The following is a description of a gene set: Human Gene Set: GSE14308_TH2_VS_NATURAL_TREG_DN Genes down-regulated in comparison of Th2 cells versus natural regulatory T cell (Treg). studied in species Homo sapiens Multipotential naïve CD4+ T cells differentiate into distinct lineages including T helper 1 (Th1), Th2, Th17, and inducible T regulatory (iTreg) cells. The remarkable diversity of CD4+ T cells begs the question whether the observed changes reflect terminal differentiation with heritable epigenetic modifications or plasticity in T cell responses. We generated genome-wide histone H3 lysine 4 (H3K4) and lysine 27 (H3K27) trimethylation maps in naïve, Th1, Th2, Th17, iTreg, and natural (n)Treg cells. We found that although modifications of signature cytokine genes (Ifng, Il4, and Il17) partially conform to the expectation of lineage commitment, critical transcription factors such as Tbx21 exhibit a broad spectrum of epigenetic states, consistent with our demonstration of T-bet and IFN-gamma induction in nTreg cells. Our data suggest an epigenetic mechanism underlying the specificity and plasticity of effector and regulatory T cells and also provide a framework for understanding complexity of CD4+ T helper cell differentiation. from publication Wei G, Wei L, Zhu J, Zang C, Hu-Li J, Yao Z, Cui K, Kanno Y, Roh TY, Watford WT, Schones DE, Peng W, Sun HW, Paul WE, O'Shea JJ, Zhao K (PMID 19144320), and this is the list of marker genes: TNRC6C, MEX3D, CMPK2, TAP2, WDR83OS, LIMD1, SEPTIN4, MCM9, PCMTD1, BAIAP3, RNASE6, HTRA2, GRIA2, PYCR2, PPP2R2B, BOD1L1, CDH9, ARV1, STARD5, SLC22A15, TNF, PURG, IVD, FAM13B, ACSF2, PDXK, ZMPSTE24, OSBPL8, CHMP1A, USP7, RBM11, BSDC1, MIA3, RNF31, TES, RBM12, LRCH3, USP32, DGAT2, TSPAN5, FAM241A, FAHD2A, SCN2A, CTU1, TUBGCP5, MKLN1, GSK3A, HEPACAM2, PDZK1IP1, SNX33, RPS6KA3, TMEM35B, CXCL10, CHRNA2, TBX6, EFR3A, CLCN2, LIMS4, GLIPR1L1, DCTN2, TSPAN6, HPCAL1, MUS81, DALRD3, COPA, RNASE4, ASAP2, ZNF280D, FUT11, ACTR10, DMAC2L, PNCK, GRAMD1C, PAN3, TSPO2 (translocator protein 2), SLC16A5, FAM120C, JARID2, IKZF1, MANSC1, KLHL12, BRD9, AP2A1, MRPL24, CAMSAP2, ERBB3, ANKLE2, ZHX2, UCK1, TOP2B, YWHAB, IDE, SYDE1, PTGES2, ATXN7, B4GALT6, DAG1, IRF6, QTRT2, COL23A1, CBFA2T2, SLC35B3, PABPC1L, HYKK, CDON, EXT1 (NCBI Gene Id 3966), HADHB, SEPSECS, PREX1, KERA, DHX30, SLC34A3, WASHC2A, NFKB1, HERC2, JPH3, PTTG1, NCOA2, SPRING1, DHCR7, CLASRP, PPP2R2A, TTF1, ACP3, SNAPC4, MSS51 (NCBI Gene Id 118490), FMNL3, EDC3, ETS1, UCKL1, GABRR2, GALNT4, HCN3, SPPL3, TEF, ACVR1B, ATG2A, RCSD1, HEG1, TESK1, HNRNPL, ATXN7L3B, GTPBP6, SMARCA4, CLN3, ZSCAN2, VIPR1, LEPR, TEX12, TAPT1, CEP164, C2CD5, SLC9A9, KCNC2, PPP1R21, FASLG, ATMIN, SERINC2, CHIT1, CREB1, KIAA1958, TSPAN32, MROH3P, DCLK1, GNG7, ZFAT, HES6, ARSK, OR7C1, ROGDI, CLCN7, DNAJB14, ZNF598, NFKBIE, COPS7A, DDRGK1, SERPINH1, MYCBP2, SESN3 (NCBI Gene Id 143686), MBOAT7, UPK2, PPM1D, SELENOW, OPA1, CNR2, CPSF1, SLC30A1, GADD45B, HSPBAP1 (HSPB1 associated protein 1), CATSPERG (cation channel sperm associated auxiliary subunit gamma), UNC13D, UBR1, PITPNM1, PAPOLG, RP1, DEF8, PNPT1, FAM216B, ARMCX2